The following is a description of a gene set: Torsion dystonia studied in species Homo sapiens Sustained involuntary muscle contractions that produce twisting and repetitive movements of the body. Human Gene Set: HP_TORSION_DYSTONIA, and this is the list of marker genes: PRRT2, THAP1, HPCA, TUBB4A, TOR1A, SLC2A1, ADAR, TAF1